The following is a description of a gene set: studied in species Mus musculus Mouse Gene Set: GOBP_RESPONSE_TO_VIRUS Any process that results in a change in state or activity of a cell or an organism (in terms of movement, secretion, enzyme production, gene expression, etc.) as a result of a stimulus from a virus., and this is the list of marker genes: Oas1e, Trim7, Trim32, Atad3a, Foxp3, Bnip3l-ps, Oasl1, Irf2, Flt3, Flicr, Rps15a, Nt5c3, Rigi, Cct5, Il6, Il1b, Polr3e, Hspb1, Usp44, Ccl19, Yju2b, Hsp90aa1, Ddx1, Gbf1, Rnf135, Gbp2, Ifnb1, Il23a, Lcn2 (NCBI Gene Id 99344), Ifitm3, Trim5 (tripartite motif-containing 5), Abcf3, Gpr146, Mlkl (NCBI Gene Id 74568), Eif2ak2, Muc19, Ifih1, Ifi203-ps, Akap1, Atg5, Exosc5, Selenok, Trim65, Pycard, Oas1f, Ifna7, Ifi209, Itgb8, Il12a, Nlrp1b, Trim30d, Rb1cc1, Mov10, Dicer1, Ifit3b, Trim12c, Mtor, Gtf2f1, Fv1, Fgl2, Garin5a, Duox2, Polr3c, Hcfc2, Oas2, Itgax, Serinc3, Crebbp, Apobec1, Zdhhc11, Ddx41, Bcl2l1, Lgals9, Trim28, Irgm2 (NCBI Gene Id 54396), Gm12250, Chuk, Tlr9, Atg7, Ube2w, Oas1b, Kcnj8 (potassium inwardly-rectifying channel, subfamily J, member 8), Unc93b1, Zdhhc1, Rnase6, Morc3, Pml, Ifit1bl2 (NCBI Gene Id 208029), Ccl5, Acta2, Bcl2, Isg15, Trim56, Oas1a, Pde12, Ddx56, Usp20, Trim30a, Becn1, Ifitm1, Ccl19-ps4, Riok3, Epg5, Ifna12, Odc1, Il15, Zmynd11, Penk, Trim35 (tripartite motif-containing 35), Gm11772, Ticam2, Ppm1b, Skp2, Rnf26, Ifnl2, Eif2ak4, Apob, Lyst, Cnot7, Slfn9, Ndufaf4, Tmem120a, Irf7, Ifnar2, Hyal3, Chmp3, Ccl19-ps5, Vwce, Sap30bp, Ifi203, Il10rb, Klra8, Vapb, Ifit1bl1, Smpd1, Itgb6, Pim2, Mavs, Traf3ip1, Ifi44l, Agbl5, Nmb, Gpam, Ube2n, Cd37, Trim38, Dhx15, Polr3b, Spon2, Ifna5, Bnip3 (NCBI Gene Id 12176), Gbp5, Fmr1, Trim6, Ifngr1, Rtp4, Senp7, Tlr8, Ifi207, Zc3h12a, Phb2, Mmp12, Heatr9, Irf5, Cxcl9, Exosc4, Il4, Agbl4, Tbx21 (T-box 21), Atg16l1, Rnf26rt, Mndal, Trim13, C1qbp, Dhx9, Pmaip1, Elmod2, Traf3, Polr3f, Cd40, Ifi27l2b, Pou2af1, Irf1, Batf3, Treml4, Zcchc3, Ifi206, Ptprc, Trim55, Aicda, Dclk1, Mx2, Tlr13, Ifitm6, Eef1g, Ifne, Kctd9, Ddx3x (DEAD box helicase 3, X-linked), Sting1 (stimulator of interferon response cGAMP interactor 1), Tlr7, Rnf216, Gsdme, Usp18, Dus2, Ikbke, Il21, Mbl2 (mannose-binding lectin (protein C) 2), Ddx17, Ifitm7, Gbp4, Plscr1, Setd2, Ifi208, Hyal2, Rab2b, Ttc4, Ifnk, Gpr108, Bnip3l, Oasl2, Oas1h, Tarbp2, Cd2ap, Ivns1abp, Atg12, Lyset, Ticam1, Atf2, Clpb, Nfkb1, Rnf185, Mill1, Trim52, Ddit4, Mul1, Il27, Ncbp1, 2410002F23Rik, Calr, Gata3, Ifna11, Trim11, Nmi, Ifi213, Trim26, Irak3, Clu, Dhx16, Lgals8, Gbp7, Trim30b, Trim25, Nlrp6, Armc5, Arf1, Ifi214, Nlrp9b, Gli2, Bst2, Trim34b, Casp1, Dhx58, Cxcl10, Polr3d, Uap1, Il12rb1, Ifit1, Slfn8, Adar, Prkra, Npc2, Nlrp3, Zbp1, Il12b, Oas1c, Ifna9, Stmn1, Gbp2b, Oas1d, Stat2, Nt5c2, Rnasel, Hyal1, Chrm2, Psma2, H2-Q7, Traf3ip3, Ddx60, Ccl19-ps6, Ifit3 (NCBI Gene Id 433243), Cd207 (CD207 antigen), Ilrun, Unc13d, Shfl, Spn, Ifna4, Apobec3, Map3k14, Ifna2, Xpr1, Aup1, Tbk1, Rrp1b, Isg20, Trim44, Serinc5, Crcp, Atg14, Tlr3, Rela, Mapk14, Htra1, Ercc6, Ripk3 (NCBI Gene Id 76562), Lsm14a, Phb1, Abcc9, Trim41, Nck1, Tnf, Rheb, Tnfsf4, Nlrp1a, Cd86, Zmpste24, Polr3g (NCBI Gene Id 67486), Mx1, Smarca5, G3bp1 (G3BP stress granule assembly factor 1), Tspan32, Traf3ip2, Samhd1, Pcbp2, Card9, Ifitm2, Smurf1, Ifna1, Dhx36, Ifna6, Trim21, Tomm70a, Cdk6, Trim27, Hes1, Creb3 (NCBI Gene Id 97162), Traf6, Nlrc5, Ccl19-ps1, Itch, Ccl19-ps3, Slc38a8, Trim8, Irf3, Ncbp3, Ncr1, Oprk1 (NCBI Gene Id 18388), Dtx3l, Mapk11 (NCBI Gene Id 19094), Ifng, Trim31, Aim2, Nmbr, Ilf3, Ext1, Ptpn22, Zc3hav1, Trex1, Sin3a, Acod1, Oas1g, Ifi27l2a, Mst1r, Pqbp1, D1Pas1, Rsad2, Usp17le, Sertad3, Ifit2, Smad3, Pla2g10, Bax, Cd8a, Znfx1, Stat1 (signal transducer and activator of transcription 1), Ddx21, Prf1 (perforin 1 (pore forming protein)), Ifnl3, Il33 (interleukin 33), F2rl1, Hif1a (NCBI Gene Id 15251), Crebzf, Cxadr, Tgfb1, Wdfy4, Fadd, Trim30c, Marchf2, Uri1, Ifna13, Oas3, Ifngr2, Myd88, Polr3h, Cgas, Polr3k, Tgtp1, Trim12a, Rpsa, Trim15, Il17ra, Il23r, Trim34a, Ifi44, Irgm1, Tagap, Igtp, Bcl3, Usp29, Pou2f2, Parp9, Vamp8, Mid2, Ifnlr1, Ifnar1, Usp27x